Given this list of marker genes FOXP3, IL4, CLCF1, BCL6, STAT6, NDFIP1, TNFSF4, here is a description of the gene set: Human Gene Set: GOBP_REGULATION_OF_ISOTYPE_SWITCHING_TO_IGE_ISOTYPES species: Homo sapiens Any process that modulates the frequency, rate or extent of isotype switching to IgE isotypes.